Given this list of marker genes Sike1, Strn3, Wwc2, Ajuba, Slmap, Mapk14, Vgll4, Limd1, Sirt1, Ppp2r1a, Wtip, Vcp, Map2k3, Mark3, Wwc1 (WW, C2 and coiled-coil domain containing 1), Strip1, Cit, Mob4, Ppp2ca, Dlg5, Src, Strn4, Shank2, here is a description of the gene set: species: Mus musculus Mouse Gene Set: GOBP_NEGATIVE_REGULATION_OF_HIPPO_SIGNALING Any process that stops, prevents, or reduces the frequency, rate or extent of hippo signaling.